Given this list of marker genes PAOX, SMOX, here is a description of the gene set: Polyamine oxidases (PAOs), like MAOs, are also FAD-dependant and form aldehydes and hydrogen peroxide. PAOs are approximately 60KDa in size, are monomers and are located in peroxisomes. They act on endogenous polyamines as well as some xenobiotics. The polyamines of the spermine and spermidine families are important physiologically as they mediate cell function and growth and also play a role in programmed cell death. The balance between biosynthesis, degradation and uptake of these polyamines is strictly controlled in cells and the PAO system is one of a set of enzymes that maintains this regulation (Tabor & Tabor 1984, Benedetti 2001). Reactome Pathway: PAOs oxidise polyamines to amines part of: Amine Oxidase reactions studied in species Homo sapiens